The following is a description of a gene set: Human Gene Set: GOBP_RESPONSE_TO_AMYLOID_BETA species: Homo sapiens Any process that results in a change in state or activity of a cell or an organism (in terms of movement, secretion, enzyme production, gene expression, etc.) as a result of a amyloid-beta stimulus., and this is the list of marker genes: GRIN1, LCN2, TNF, MMP13, VCAM1, BACE1, GRM5, PARP1, EPHB2, ITGA4, GRIN2A, TYROBP, CASP4, MMP9, CHRNA7, MIR146A, MIR98, MIR200A, NTRK1, IGF1R, CD36 (NCBI Gene Id 948), GSK3B, CACNA2D1, MMP2, IGF1, RAMP3, GJA1, SYK, ICAM1, FOXO3, ABCC1, TLR6, FPR2, MMP3, MIR140, LGMN, LRP1, FCGR2B (Fc gamma receptor IIb), CALCR, EPHA4, CACNA1A, CDK5, ATP1A3, HDAC2, TREM2, CACNB1, TLR4, MMP12, AGER, SNX6, PRNP, MIRLET7F1, MIR200C, PSEN1, MIR106B, NGFR, APP, ADRB2, FYN, CACNA1B